Given this list of marker genes GATA5, SLC34A2, IFIH1, HGD, NOTCH1, GBA1, NKX2-5, LMNA (lamin A/C), ZMPSTE24, FBN1, RIGI, SMAD6, MTX2, here is a description of the gene set: Cardiac valve calcification Abnormal calcification of a cardiac valve. species: Homo sapiens Human Gene Set: HP_CARDIAC_VALVE_CALCIFICATION